The following is a description of a gene set: Human Gene Set: GOBP_REGULATION_OF_RIBOSOME_BIOGENESIS Any process that modulates the rate, frequency or extent of ribosome biogenesis. Ribosome biogenesis is the cellular process that results in the biosynthesis of constituent macromolecules, assembly, and arrangement of constituent parts of ribosome subunits. species: Homo sapiens, and this is the list of marker genes: NUDT16, RBM10, USP16, MALSU1, KAT2B, METTL18